Given this list of marker genes CHADL, DEPDC7, SESN1, NODAL, TNFRSF10C, DRAM1, TYMSOS, FDXR, HSPA4L, TMTC3, BTG3-AS1, SNX20, TMEM120B, PIDD1, TRIAP1, FBXW7, BBC3, ETV7 (ETS variant transcription factor 7), BTG2, PPFIBP1, RRM2B, ANKRA2, SNORA24, TP53TG1, TRIM22, NOTCH1, CDKN1A, PLCL2, RPS27L, COMP, CFAP57, E2F7, DNAI3, CES2 (carboxylesterase 2), THSD1, GM2A, ZNF219, NOPCHAP1, FAS, POU2F2, UNC5B-AS1, DDB2, FBXO22, LINC00926 (long intergenic non-protein coding RNA 926), FRMD4A, ASGR1, DNAJB4, PAPPA, OR11A1, FOXP1, MDM2, NDUFAF8, PRF1, ACBD6 (acyl-CoA binding domain containing 6), SCN9A, CAVIN2, JAM3, VWCE (von Willebrand factor C and EGF domains), NINJ1, MTCL1, TGFBI, ICAM5, CCNG1, RAD51C (RAD51 paralog C, NCBI Gene Id 5889), POLH, ZNF79, FGFBP3, RAP2B, STING1, GDF15, PPM1D, TIGAR, CABYR, MAGT1, ANKRD33B, ALCAM, MICALL2, BLOC1S2, PALM2AKAP2, LASP1NB, RTTN, TP53INP1, here is a description of the gene set: Human Gene Set: WARTERS_RESPONSE_TO_IR_SKIN Although skin is usually exposed during human exposures to ionizing radiation, there have been no thorough examinations of the transcriptional response of skin fibroblasts and keratinocytes to radiation. The transcriptional response of quiescent primary fibroblasts and keratinocytes exposed to from 10 cGy to 5 Gy and collected 4 h after treatment was examined. RNA was isolated and examined by microarray analysis for changes in the levels of gene expression. Exposure to ionizing radiation altered the expression of genes across both cell types. Changes in RNA expression could be arranged into three main categories: (1) changes in keratinocytes but not in fibroblasts, (2) changes in fibroblasts but not in keratinocytes, and (3) changes in both. All of these changes were primarily of p53 target genes. Similar radiation-induced changes were induced in immortalized fibroblasts or keratinocytes. In separate experiments, protein was collected and analyzed by Western blotting for expression of proteins observed in microarray experiments to be overexpressed at the mRNA level. Both Q-PCR and Western blot analysis experiments validated these transcription changes. Our results are consistent with changes in the expression of p53 target genes as indicating the magnitude of cell responses to ionizing radiation. studied in species Homo sapiens from publication Warters RL, Packard AT, Kramer GF, Gaffney DK, Moos PJ (PMID 19580510) Genes displaying an ionizing radiation response in the human skin cell samples.